The following is a description of a gene set: Any process that activates or increases the frequency, rate or extent of ligase activity, the catalysis of the ligation of two substances with concomitant breaking of a diphosphate linkage, usually in a nucleoside triphosphate. studied in species Mus musculus Mouse Gene Set: GOBP_POSITIVE_REGULATION_OF_LIGASE_ACTIVITY, and this is the list of marker genes: Mid1ip1, Ripk3, Gclm, Atpsckmt, Xrcc4